The following is a description of a gene set: from publication Amit I, Garber M, Chevrier N, Leite AP, Donner Y, Eisenhaure T, Guttman M, Grenier JK, Li W, Zuk O, Schubert LA, Birditt B, Shay T, Goren A, Zhang X, Smith Z, Deering R, McDonald RC, Cabili M, Bernstein BE, Rinn JL, Meissner A, Root DE, Hacohen N, Regev A (PMID 19729616) species: Homo sapiens Genes up-regulated in comparison of dendritic cells (DC) stimulated with Pam3Csk4 (TLR1/2 agonist) at 12 h versus DC cells stimulated with Gardiquimod (TLR7 agonist) at 12 h. Human Gene Set: GSE17721_PAM3CSK4_VS_GADIQUIMOD_12H_BMDC_UP mouse primary BMDCs were stimulated with tlr ligands and gene expression changes were profiled on Affymetrix arrays, and this is the list of marker genes: RPS10, RPL13A, DOLPP1, ARPC1A, UCN, TMEM119, TDRP, HEXB, STMN1, CUEDC2, DBI, SLC19A2, NDUFB2, MED29, CCDC22, SESN3, CIB2, IFITM10, ST6GAL1, SWI5, DPY30, ZNF148, TRAPPC6A, GIPC3, EPHA6, INTS6L, PREB, ZMPSTE24, FIBIN, ACADM, CPSF3, RPS16, SIRT4, COQ9, KL, RMND5B, PKD2L2, AKR1B15, ZNF638, ATP2A1, GNPAT, ACBD6, EIF3I, CLPP, HTATSF1, SLC35B1, LMNA, DUSP3, ORMDL1, MRPL33, DGLUCY, C15orf40, CHURC1, KRT82, SLC13A2, MYF5, OLFM1, SDAD1, MRPL15, TMEM214, TMEM97, UNC119, KLHDC3, KLF9 (KLF transcription factor 9), SLC34A2, UQCC1, PBDC1, DNMT3L, PSMB5, PTGR1, FKBP3, KIF21B, ARHGDIB, RPL7A, UBE2C, NDUFV2, SLC22A13, SNF8 (SNF8 subunit of ESCRT-II), TRAPPC1, MRPL51, RAD54L2, GLRX3, GSTM1, DNAJC3, TBX1, S100A6, ODR4, COMMD7, TXN2, HVCN1, RPL23A (NCBI Gene Id 6147), SLC66A1, CCT8, GPD2, TECTA, PCLO, AK3, SLC39A1, MRPS17, CIDEB, HSPE1, C19orf53, H2AZ1, LRFN1, EPB41, FASN, IMP4, MPND, TMEM126A, KCNAB2, STMP1, CSRP3 (NCBI Gene Id 8048), RPL14, WBP1, DUSP19, PRDX6, C2orf42, HOXC13, UFM1, STK10, THAP11, POLD4, GJC1, SYNJ2BP, PRDX3, SLC10A3, PCCA, ACOT7, GPR180, PRMT7, SQLE, PGK1, GNL3, ZNHIT3, B4GALNT1, NHERF2, NDUFA9, GFM1, SASH3, CDA, COX20, RNF26, NDUFS6 (NADH:ubiquinone oxidoreductase subunit S6), CRAT, FAM210B, CD247, MTHFD1 (NCBI Gene Id 4522), PLPBP, ATP5MF, RNASEH2C, DHRS7, SH3BGRL3, SUN1, PSMB3, POP5, ELOVL1, PKM, SDHAF1, FRRS1, UTP20, H2AX, AARSD1, CCT4, FERMT2, MFSD10, MECR, CLCN4, TTC3, GDI2, NDUFA4, SREBF1, LPGAT1, TM7SF2, ABCB10, PCDHB13, ATAD3A, HADHB, CHEK2, ARMH4, MGST1, PNKD, SFXN3, MAPK14, ZNRD2, NDUFA13, LAS1L, KIFC3, PIGS, E2F6, C3orf62, ESR1, CKS1B, HINT3, BDH1, GPR155, BBLN, SFXN1, KGD4, ECI2, GTF3A